Given this list of marker genes ADAP2, MYL2, ADAM32 (NCBI Gene Id 203102), AMBN, SCNN1G, SHE, CKS2, CYP3A4, PUS1, JUNB, SLC39A11, GPR34, MPPED1 (metallophosphoesterase domain containing 1), TEP1, CYP2B6, KLHL36, PRRG4, CTXN3, ZFHX3, JHY, EIF5A2, HHAT, EMX2, GADD45B, NPFF, GALNT13, PCOLCE, PRR11, PER1, ADH4, ADAD1, LBX2, TEK, FOXB2, C15orf39, COL6A5, ADAMTS2, BATF, TUFT1, KCNJ9, CDH8, MYO18A, TTC9, ANK3, KLF4, MUSTN1, HMX2, OSBPL10, SCN10A, C10orf62, FHIT, DYNLT2B, DDAH1 (dimethylarginine dimethylaminohydrolase 1), KCNK13, RRAD, TNFAIP3, C17orf58, TNNT2, RGS1, ANAPC10, PRMT8 (NCBI Gene Id 56341), CCDC167, DNAI1, SNAI3-AS1, SH3RF2, ORC1, RBP2, GPRC5D, DEUP1, DCAKD, DSG1, KGD4, FAM210B, ANKRD54, PAXX, MRPS11, GNAL, TFPI2, NEXN, TM4SF1, PTH2R, AGTRAP, PMEL, SRP19, FGF8, UNC79, DUSP1 (dual specificity phosphatase 1), HSPA1A, ZC3H12C, NPC1L1, SLC27A5, TLE1, ASL, PIM3, SLC44A4, ZNF830 (zinc finger protein 830), MTCL1, NIPAL4, RBFOX1, WNT3, NOXO1, CLSTN3, SLC52A3, CCDC39, OCEL1, SLC16A11, BNC1, KCNU1, ANKRD33, HR, SPINK4, FAM151A, MRGPRX2, WDR17, C1R, AKT1S1, MROH2B, FRAT2, HGF, DOLPP1, CDH15, TAL1, ASGR1, ZMYM3, KCNK6, HOXB9, SIAH2, PPP1R3F, SARM1, SPTBN2, ANKRD7 (NCBI Gene Id 56311), DSG2, CYP26B1 (cytochrome P450 family 26 subfamily B member 1), AATK, CACNA2D2, UCN2, FOSB, NKX3-1, ACOXL, CHRNB4, RFLNA, DCN, NKX2-4, SYNPR, SOX4, NRXN1, IL20RB, BAMBI, RAD18, HSFY2, CASS4, FKBP6, HOGA1, HEXIM1, GEM, ALCAM, TMPRSS11A, MANSC1, CACNA1D, C16orf78, SIK1, SLC29A1, SYT6, ETV5 (NCBI Gene Id 2119), PKD2L2, CEBPB, YDJC, IFNG, SPA17, TTC21A, SERPINB5, SCX, GLRB, RCOR2, IGHG1, PHGDH, ARMH4, LONRF3, CDX4, PTK7, PMFBP1, WNT2B, CD69, UBL5, AVPR1B, CFAP206, DIRAS2, SLCO4A1, RD3, PMM2, AMMECR1, RND3, SYT10, PPP1R15A, DNASE2B, OSM, PAPPA2, USP53, here is a description of the gene set: Transcription factors that regulate quiescence, proliferation, and homing of lymphocytes are critical for effective immune system function. In the present study, we demonstrated that the transcription factor ELF4 directly activates the tumor suppressor KLF4 downstream of T cell receptor (TCR) signaling to induce cell cycle arrest in naive CD8+ T cells. Elf4- and Klf4-deficient mice accumulated CD8+CD44hi T cells during steady-state conditions and generated more memory T cells after immunization. The homeostatic expansion of CD8+CD44hi T cells in Elf4-null mice resulted in a redistribution of cells to non-lymphoid tissue due to reduced expression of the transcription factor KLF2, and the surface proteins CCR7 and CD62L. This work describes the combinatorial role of lymphocyte-intrinsic factors in the control of T cell homeostasis, activation and homing. Genes down-regulated in comparison of naive CD8 T cells from ELF4 defficient mice versus those from wild type animals. Human Gene Set: GSE15324_ELF4_KO_VS_WT_NAIVE_CD8_TCELL_DN species: Homo sapiens from publication Yamada T, Park CS, Mamonkin M, Lacorazza HD (PMID 19412182)